The following is a description of a gene set: species: Homo sapiens Modulates the activity of the enzyme 1-phosphatidylinositol-3-kinase activity. Human Gene Set: GOMF_1_PHOSPHATIDYLINOSITOL_3_KINASE_REGULATOR_ACTIVITY, and this is the list of marker genes: PIK3R5, PIK3R6, CCKBR (NCBI Gene Id 887), PIK3R1, PIK3R2 (phosphoinositide-3-kinase regulatory subunit 2), PIK3R3